Given this list of marker genes Map3k5, Pygl, Ppif, Peli1, Nupr1, Birc2, Ipmk, Ripk1, Casp1, Birc3, Parp1, Pgam5, Tlr3, Nlrp6, Map3k7, Mutyh, Nol3, Fas, Adprs, Cav1, Casp6, Slc25a4, Mlkl, Rnf31, Traf2, Ripk3, Ybx3, Nlrp1a (NLR family, pyrin domain containing 1A), Fasl, Mapk8, Itpk1, Atg9b, Ninj1, Spata2, Cflar, Asah1, Irf3, Casp8, Trpm7, Dnm1l, Fzd9, Cyld, Atg9a (autophagy related 9A), Tnf, Zbp1, Trp53, Bok, Aifm1, Fadd, Bax, Alkbh7, Rbck1, Tspo, here is a description of the gene set: Mouse Gene Set: GOBP_PROGRAMMED_NECROTIC_CELL_DEATH A necrotic cell death process that results from the activation of endogenous cellular processes, such as signaling involving death domain receptors or Toll-like receptors. species: Mus musculus